Given this list of marker genes Shh, Ccnb1-ps, Ihh, Bbs1, Smo, Ptch1, Ccnb1, Dhh, here is a description of the gene set: studied in species Mus musculus Binding to a patched (ptc) protein, a receptor for hedgehog proteins. Mouse Gene Set: GOMF_PATCHED_BINDING